Given this list of marker genes Nfkbia, Mapk11, Peli2, Tab3, Nfkb2, Nfkbib, Map2k6, Mapk3 (mitogen-activated protein kinase 3), Jun, Ppp2r1b, Mapk9, Ube2v1, Lrrc14, Fos, Ager, Tifa (NCBI Gene Id 211550), Mapk8, Ecsit, Cul1, Vrk3, Irak1, Tab1, Map2k7, Nfkb1, Ppp2r5d, Hmgb1, Rps6ka5, Nlrx1, S100b, Ube2n (ubiquitin-conjugating enzyme E2N), Map2k4, Nkiras1, Dusp6, Dusp7, Casp8, Rela, Nlrc5, Rps27a, Tab2, Tirap, Ubb, Mapk7, Map3k8, Mapk14 (NCBI Gene Id 26416), Ikbkb, Map2k3 (NCBI Gene Id 26397), here is a description of the gene set: This event has been computationally inferred from an event that has been demonstrated in another species.<p>The inference is based on the homology mapping from PANTHER. Briefly, reactions for which all involved PhysicalEntities (in input, output and catalyst) have a mapped orthologue/paralogue (for complexes at least 75% of components must have a mapping) are inferred to the other species. Reactome Pathway: Toll Like Receptor TLR6:TLR2 Cascade studied in species Mus musculus part of: Toll Like Receptor 2 (TLR2) Cascade electronically inferred by orthology from the curated human pathway